Given this list of marker genes KIF22, TRAPPC12, CHMP4BP1, CDT1 (chromatin licensing and DNA replication factor 1), ZW10, CHMP2B, TTK, KAT2B, CHMP3, DCTN2, NDC80, KIF2B (NCBI Gene Id 84643), KIFC1, NEK2, PIBF1, CDC23, SPC25, CHMP1B, SIRT2, SKA1, BECN1, NSL1, CDCA8, SEH1L, NUF2 (NCBI Gene Id 83540), ANKRD53, SGO1, KNL1, BOD1, BIRC5, SPC24, AURKC, VPS4B, MIS12, KPNB1, MAD1L1, KAT5, CDCA5, CHMP5, TEX14, MEIOC, DSN1, CHMP4C, SIRT1, CCDC66, ZNF207, TTL, CCNB1 (cyclin B1), GEM, VPS4A, CHMP1A, PMF1, PDCD6IP, PINX1, MLH1, BUB3, ZWINT, MAP1S, HNRNPU, ZWILCH, MAPRE1, CENPE, SKA2, CENPF, KIF14, ECT2, EML4, SEPTIN1 (septin 1), SPICE1, CHMP7, EML3, NUP62, RACGAP1, RAB24, KNTC1, CDC42, RB1, RRS1, RMDN1, FAM83D, RAB11A, SPAG5, SPDL1, AURKB, PSRC1, INCENP, ABRAXAS1, CHMP4A, NUMA1, CHMP4B, RCC2, CENPQ, KIF2C, NUDC, DYNC1H1, CENPC, CHAMP1, APC, CHMP2A, KNSTRN, CHMP6, KIF18A, CUL3, CEP55, ABRAXAS2, SKA3, CDK1, here is a description of the gene set: species: Homo sapiens Human Gene Set: GOBP_METAPHASE_CHROMOSOME_ALIGNMENT A chromosome localization process whereby chromosomes are positioned in a specific order and orientation at the metaphase plate (spindle equator), during chromosome segregation. This alignment ensures that each daughter cell will receive the correct number of chromosomes during cell division.